Given this list of marker genes CYB5RL, DZIP3, BMPR2, IFT20, EIF5A, CDKAL1, PPP4R3A, SNX19, PDPK1, TXN2, CNN3, ASS1, ATG12, DBT, NONO, IL2RG, ZNF580, SPEN (NCBI Gene Id 348488), ANKRD6, UBR2, ZNF277, CCDC88C, ATF5, ALB (albumin), DHFR (NCBI Gene Id 203373), RPS10P5, HOPX, MMRN1, TRBC2, AKR1D1, HGSNAT (NCBI Gene Id 8119), ARMC8, SLC6A8, CFD, CX3CR1, BLTP1, ZBTB1, SERPINF1, PKP4, NFIB, LRIF1, ST8SIA4, TPR, SIGLEC6 (sialic acid binding Ig like lectin 6), LAMTOR3, DDX39B, ABCA11P, GUCY1A1, MMUT, ALG13, TOMM22, IL13RA1, NCAM2, PTPRCAP, PLAG1, PRRC2C, GOLGA8A, CES1, ALDOC, ZSCAN18, ALDH2, ANKRD11, POLD4, SOCS1, F2R, CR1, EGLN3, RRAGD, SFSWAP (splicing factor SWAP), RAB3GAP2, DDX50 (NCBI Gene Id 79009), CASP2, MEF2A, SLC2A3, KANSL1L, RGS10, BNIP3, BANP, AMFR, TSPAN32, CEPT1, MYCBP, BPTF, CD24, IFI44, PLPP3, IFI6, NFAT5 (nuclear factor of activated T cells 5), BEND5, IRAK4, RASGRP3, TPI1, PTPRB (NCBI Gene Id 5787), ZNF175, MT1F, SPP1, GPSM3, SIK2, ANKRD12, TXNIP, EZR, MSMO1, PF4V1, RLF, TMEM45A, MACROH2A1, ZFR, ZNF302, LDLRAD4, IFT74, GABPB1-IT1, EFCAB14, PLG, SNX10, GRIK5, POU2F1, MAP3K2 (NCBI Gene Id 51777), VAMP4, CCND1, SLC16A3, BRWD1 (NCBI Gene Id 54146), P4HA2, SAFB, SRSF6, UTS2, CANT1, RPS3AP5, FEM1C, PTPN22, S100P, ASNS, PGGT1B, TMOD3 (tropomodulin 3), APP, ZKSCAN1, LGALS3BP, BACE2, HNRNPH1, EPRS1, HSPA1B, MIR3648-1, MED13L, RABGAP1, EPX, KLHL24, PCM1, OTUD4, ZNF140, MT2A (NCBI Gene Id 4502), ID1, GPR18, KDM5B, CD9, MAPRE2, SP140, RPL36, BAX, ADGRG1, C1orf54, NOPCHAP1, MT1X, CDV3, RECK, CALD1, ERAP1, TM6SF1, CCPG1, MRPS18B, CCNE2, AXL, N4BP1, IRAG2, ZFX, CD200, ZSCAN12, VENTXP1, TESK1, AGFG1, ATP9B, TRIM52-AS1, RRAS, MARK4, RBM25, PSG1, RWDD1, AFG2B, NUTF2, ACTR2, CREB1, AP3D1, FZD2, SLC50A1, THBS1, CYLD, CILK1, PMP2, ZNF609, FCGR2B, ELL, SMG7, HIGD2A, KLF13, SCN9A, MEAK7, STC2, ZNF93, TBL1XR1, HSPA6, PTAFR, GPRC5C, P4HA1, RPS21, MEOX1, MT1G, LIAS, MXI1, GALNT3, HSPA1A, RSRP1, H4C3, CACYBP, TSPOAP1, ABRAXAS2, PAK2, SET, NLK, MINDY3 (MINDY lysine 48 deubiquitinase 3), APPBP2, TMEM156, UBE2W, PPBP, PLAUR, MT1H, RRN3, WDR33, TRDC, CCR2, MXRA7, FAM13A, ZNF322, LRRFIP1, TLK1, TRAPPC2, TRADD, LRRC1, SOS2, GADD45A, TNS1, L3MBTL1, GYPA, ARMH3, DUSP9, UBE2D1, ZNF292, VLDLR, IL17RB, TMPO, UGCG, RRAS2, ANAPC5, RIOK3, FAM200C, RNLS, MAP4K5, PGM3, MTRF1, THNSL1, JCHAIN, S100PBP, H6PD, DDX17 (NCBI Gene Id 10521), ATP2A3, CASP8, PF4, PTPRO, HACD3, AIRIM, MAP3K1, PEX11A, MT1E, KRIT1, here is a description of the gene set: Genes down-regulated in hematopoietic stem cells (HSC, CD34+) cultured in a three-dimentional collagen gel compared to the cells grown in suspension. species: Homo sapiens from publication Oswald J, Steudel C, Salchert K, Joergensen B, Thiede C, Ehninger G, Werner C, Bornhäuser M (PMID 16166251) Human Gene Set: OSWALD_HEMATOPOIETIC_STEM_CELL_IN_COLLAGEN_GEL_DN CD34+ hematopoietic stem/progenitor cells (HSCs) reside in the bone marrow in close proximity to the endosteal bone surface, surrounded by osteoblasts, stromal cells, and various extracellular matrix molecules. We used a bioartificial matrix of fibrillar collagen I, the major matrix component of bone, as a scaffold for ex vivo expansion of HSCs. CD34+ HSCs were isolated from umbilical cord blood and cultivated within reconstituted collagen I fibrils in the presence of fms-like tyrosine kinase-3 ligand, stem cell factor, and interleukin (IL)-3. After 7 days of culture, the cell number, number of colony-forming units (CFU-C), and gene-expression profile of the cultured cells were assessed. Although the total expansion factor of CD34+ cells was slightly lower when cells were cultivated in the collagen I gel, the frequency of CFU-C was greater than in control suspension cultures. Gene-expression analysis with microarray chip technology revealed the upregulation of more than genes in the presence of collagen I. Among these, genes for several growth factors, cytokines, and chemokines (e.g., IL-8 and macrophage inhibitory protein 1alpha) could be confirmed using quantitative polymerase chain reaction. Furthermore, greater expression levels of the negative cell-cycle regulator BTG2/TIS21 and an inhibitor of the mitogen-activated protein kinase pathway, DUSP2, underline the regulatory role of the extracellular matrix. Together, these data show that the expansion of CD34+ cord blood cells in a culture system containing a three-dimensional collagen I matrix induces a qualitative change in the gene-expression profile of cultivated HSCs.